Given this list of marker genes PFN1, SETMAR, GABARAPL2, VMP1, PXK, ATP2A1, MYL3, VMA21, TPM2, PPIF, TNNT3, TLR9, AHSA1, FGF10, MYL4, UBLCP1, STRIT1, CHTOP, TP53, LTF, OXA1L, TOR1AIP2, DNAJB11, VCPKMT, DNAJC9, PFN2, HNRNPU, SLN, TNNT2, TSC1, TOR1AIP1, SNRNP70, DNAJC24, PLN (NCBI Gene Id 5350), RGN, PLSCR1, TNNI3, DNAJB2, PAM16, BRSK2, SSBP1, here is a description of the gene set: studied in species Homo sapiens Any process that modulates the rate of an ATP-dependent activity. Human Gene Set: GOBP_REGULATION_OF_ATP_DEPENDENT_ACTIVITY